Given this list of marker genes Gnat3 (G protein subunit alpha transducin 3), Gnb4, Gngt1, Gng12, Gng2, Gnb2, Gng3, Gnai3, Gnb1, Gng5, Gnai1, Gng11, Gnb3, Gng7, Gng8 (NCBI Gene Id 14709), Gnai2, Gngt2, Gng10, Gnb5, Gng13, P2ry12, Gng4 (NCBI Gene Id 14706), here is a description of the gene set: ADP signalling through P2Y purinoceptor 12 studied in species Mus musculus Mouse Gene Set: REACTOME_ADP_SIGNALLING_THROUGH_P2Y_PURINOCEPTOR_12